The following is a description of a gene set: Human Gene Set: GSE4590_SMALL_VS_VPREB_POS_LARGE_PRE_BCELL_DN studied in species Homo sapiens Cells from four develppmental stages were purified by FACS from human bone marrow samples from publication Hoffmann R, Lottaz C, Kühne T, Rolink A, Melchers F (PMID 17890238) Genes down-regulated during B lymphocyte differentiation: small pre-B II versus VPREB1+ large pre-B II., and this is the list of marker genes: PLK3 (NCBI Gene Id 1263), CDSN, KRTAP4-6, IL17RD, CATSPER1, TMSB10, C19orf38, ARHGEF12, ABLIM1, LARP1, MVD, ITGAE, NRK, NINL, KCNJ11, LIN7A, PDGFRB, DAP, DENND6A, TAFA4, CTSF, KRT75, IL18, CSRP3, PROX1, CTXN2, CMPK2, CDK5R1, IL18BP, DLK2, MINDY3, POPDC3, FZD4, TXK, ANXA5, CCR4, E2F7, TIGD3, HHATL, PPP3CA, CD163L1, CCNB2, LCE1E, PZP, AGPAT3, CDCA4 (NCBI Gene Id 55038), P2RX2, MIR9-3, TUBB2A (NCBI Gene Id 92919), CLEC7A, UBAC2, PDE6C, UAP1, NUP62CL, DNAI7, GOT1, ASIC4, CLEC16A, LIG1, ANKMY1, TNFAIP1, ESPN, BAALC (BAALC binder of MAP3K1 and KLF4), GTSF1L (NCBI Gene Id 149699), CLIC4, AGFG1, EFCAB12, PLCXD2, ILDR1, CALHM4, OSBPL3, ARRDC2, APLP2, AMER2, GREM2, SLC25A48, HEMGN, NUDT4, CDKN2C, ABI2, CALHM6, DUSP10, ADGRE5, EXT1, ZDHHC12, MNS1, DHX58, CD8B, PSPH, INPP5A, CLIP2, NME5, GZMA, ARSB, PGF, FOXA1, CD2, SLC44A4, LIX1, TMEM171, CCNF, MYO10 (NCBI Gene Id 4651), MYORG, GIMAP4, IFI27L1, NRP1, SLC39A8, IKZF3, MAGIX, CDC14B, KLF7, LCE1F, IFNA13, XXYLT1, HEG1, TES, DNAJC5G, SNX25, AMOTL1, POU2F3, ADAM19, ITGB2, EBF1, SH3BP5, UMOD, TUBB2B, KLHL25, NSG2, BSPRY (NCBI Gene Id 54836), GRAMD2B, RNF212, PTPN14, ZDHHC7, ACP5, LINGO4, UNC80, COX4I2, DUSP22, KLF2, SLAMF1, GALNT9, LIPF, TBCB, CD8A, FBP1, NOL4, LEF1, KCNA10 (potassium voltage-gated channel subfamily A member 10), DLGAP1, ATP8A2, SPRYD3, OPN3, PDLIM5, DBNDD1, SPATS2L, CIMAP1C, KCNIP2, UBA1, PDZD2, EDN2